The following is a description of a gene set: Reactome Pathway: Triglyceride biosynthesis electronically inferred by orthology from the curated human pathway part of: Triglyceride metabolism This event has been computationally inferred from an event that has been demonstrated in another species.<p>The inference is based on the homology mapping from PANTHER. Briefly, reactions for which all involved PhysicalEntities (in input, output and catalyst) have a mapped orthologue/paralogue (for complexes at least 75% of components must have a mapping) are inferred to the other species. species: Mus musculus, and this is the list of marker genes: Mogat2, Gykl1, Dgat2, Gpam, Gpat2, Agmo, Gk2